Given this list of marker genes BPNT2, NT5DC4, NT5C2, NT5DC1, NT5M, NT5E, NT5C3B, NT5C1B, BPNT1, NT5DC3, NT5DC2, NT5C, ACP3 (NCBI Gene Id 55), NT5C1A, NT5C3A (NCBI Gene Id 96002), here is a description of the gene set: Catalysis of the reaction: a nucleotide + H2O = a nucleoside + phosphate. Human Gene Set: GOMF_NUCLEOTIDASE_ACTIVITY studied in species Homo sapiens